The following is a description of a gene set: species: Homo sapiens Abnormal systemic blood pressure A chronic deviation from normal pressure in the systemic arterial system. Human Gene Set: HP_ABNORMAL_SYSTEMIC_BLOOD_PRESSURE, and this is the list of marker genes: CEP19, LRRK2, NF1, RYR1, IFT140, MTFMT, TREX1, FKBP6, CLCNKA, CEP290, XPNPEP3, ACP5, HLA-DRB1, IDUA, NFKB2, KCNJ1, STN1, SMAD6, ARVCF, BBS5, SERPINA6, PLAAT3, ELP1, TRPC6, TGFBR2, STAT4, VAC14, TNFSF4, LIPE, MMP14, CCND1, STAR, UBE2L3, HELLPAR, WDPCP, ENG, GIGYF2, FLT1 (fms related receptor tyrosine kinase 1), PAM16, MT-ND1, CYP17A1, IFIH1, MLXIPL (MLX interacting protein like), VPS35, MUC1 (mucin 1, cell surface associated), MYCN, CCN2, ACTG2, WDR19, AGT, EXT2, P2RY11, CDKN2A, CASR, DLL4, IL12B, NTRK1, HEY2, IFT27, SLC25A20, PRKAG2, FBN1, CIDEC, NEUROG3 (NCBI Gene Id 50674), ALX4, TNFRSF11A, LMNB1, METTL27, TXNRD2, GMPPA, RUNX1, ACTA2, ERCC6, MYMK, GNAS, COL3A1, STAT2, SMAD2, SLC12A3 (solute carrier family 12 member 3), NOTCH1, SLC7A7, MKKS, BRCA2, ACVRL1 (NCBI Gene Id 94), BANK1, OFD1, ALG9, SIM1, NOS3, CFB, PRKG1, SMAD3, HIRA, NEK8, COQ7, FIG4, KIF12, GNB3, BBS10, HGD, SFTPC, THSD1, CHRNA3, CELA2A, ALG5, CLDN1, RFC2, ZFX, SCARB2, ALK, DEF6, MT-TQ, SDHC, DNAJC13, MT-TF, PSMB9, F5, NCF1 (neutrophil cytosolic factor 1), GP1BB, PROP1, NSMCE2, MT-TK, IRF4, JAK2, ITGAM, HMOX1, BICC1, ASXL1, LYZ, HACE1, GTF2IRD1, BMPR2, MT-TW, BBS2, ENPP1, HSD3B2, MDM2, FH, PDE3A, SAA1, ADRA2A, TMEM270, ZNRF3, TMEM70, POU3F4, C4A, COL4A3, SLC30A9, TMEM127, HPSE2, BBIP1, HLA-B, MAX, TBX19, CYP11B1, HMGCL, FGFR2, SNCA, SCLT1, CD2AP, USP48, DLST, SLC35A2, IGHG1, INVS, BLK, CEP164, SPRY2, ATRX, AAAS, NKX2-5, TSC2, IFNG (interferon gamma), FN1, ABCC6, PTPN22, DDC (dopa decarboxylase), IQCB1, LIN28B, HEXB, EDA2R, TP53, DNMT3A, LZTFL1 (NCBI Gene Id 54585), ALMS1, BBS9, H4C3, TGFB3, VANGL1, TCF4, RPGRIP1L, ITGA8, ARL6, RREB1, GPR35, SCAPER, B2M, TBL2, BSND, SDHD, LOX, FOXA2, IDS, TNFAIP3, ELN, TRAPPC11, EGFR, SMARCAL1, LHX4, GUCY1A1, ABCG5, STX1A, EXOSC2, DCTN1, MC4R, FCGR2B, UBR1, PLIN1, DHCR7, POU2AF1, SLC12A1, SLC25A11, CLCNKB, NOTCH2, LMNA, EOGT, MOG, GSN, KIAA0319L, ZMPSTE24, NR4A2, EIF4H, SDHAF2, ACBD6, LDLR (NCBI Gene Id 3949), CYP11A1, COL4A4, POT1, AVPR2, CPOX, COL5A2, ETS1, THBD, NPHP3, APOA1, WNK1, CFHR1, BMP6, COQ2 (NCBI Gene Id 27235), ZFYVE19, HMBS, SCN2B, TRAF3IP1, DZIP1L, MYLK (NCBI Gene Id 50483), FGA, PIGM, PDCD1, RNU4ATAC, GEMIN4, TLR7, ALB, CTSH, PDE4D, CYP11B2, SDHA (succinate dehydrogenase complex flavoprotein subunit A), COMT, LMO1, TRIM28, GCH1, IFT74, HBB, ERCC8, MT-CO1, MT-ND5, PRKACA, IFT172, ADD1 (adducin 1), DEPDC5, FOXE3, CFHR3, KLHL3 (kelch like family member 3), DCDC2, REN, ARMC5, C3, FMR1, TNPO3, BBS4, MT-TC, KRT18, SCNN1A, APOB, GTF2I, ZNF365, ACTN4, THSD4, MYMX, SMAD4, WRN, PHF21A, MT-CYB, CTLA4, LIPA, ARSA, PBX1, ABCA3 (NCBI Gene Id 21), DOCK6, MEF2A, ANGPTL6, HLA-DQB1, TNFSF15, GTF2IRD2, FMO3, GLI2 (NCBI Gene Id 50806), SLC37A4, SDHB, MRAP, MMEL1, OSGEP, ACE, CFI, IFT56, BANF1, POU1F1, IL12RB1, EPOR, MAFB, NFIX, CTNNB1, ABCG8, SERPING1, TERT, XYLT1, SPG11, PDE11A, MEN1, SP110, BRCC3, COL5A1, ABCB6, MYH11, ITCH, LRP6, MT-ND6, IL10, VHL, CUL3, KCTD1, MPI, GATA5, JMJD1C, JAZF1, INF2, NOTCH3, SDCCAG8, C4B, CCR6, PKD2, PKD1, DNASE1, CLIP2, CALR, KCNJ5, EDA, CLCN2, ABCB4, SOX10, CACNA1H, CYP3A5, CDKN2B, MC2R, CYP21A2, HLA-DPB1, PHOX2B, SLC30A10, CORIN, IMPDH2, ERCC4, BNC2, DNAJC30, CEP83, SCNN1G, CD46, CACNA1D, PTGIS (prostaglandin I2 synthase), ARHGAP31 (NCBI Gene Id 57514), SHPK, TBX1, TSC1, SCNN1B, DYRK1B, TULP3, TGFBR3, ADAMTSL4, H19, DIS3L2, SPIB, PAX2, TGFB2, GPR101, VPS37D, MMP2, SLC2A10, MT-TS2, ASL, HESX1, SRSF2, CDKN1A, PXK, NR3C2, TNFRSF11B, PIGA, LRIG2, COL1A1, CBL, WT1, NNT, GPC3, MGP, HCRT, KDM1A, FARSB (phenylalanyl-tRNA synthetase subunit beta), TTC8, BBS1, STOX1, USP8, SUGCT, TRIP13, MT-TV, XYLT2, TGFBR1, REST, IRF5, UFD1, MLX, SOX3, CDH23, HNRNPK, LIMK1, TNNT2, SEC61A1, GLA, NPHP4 (NCBI Gene Id 261734), CFAP418, TNIP1, GIMAP5 (GTPase, IMAP family member 5), IRAK1, PSAP, GNB2, LDLRAP1, PPOX, DBH (dopamine beta-hydroxylase), MECP2, LEMD3, MBTPS2, MT-CO2, POU6F2, CHCHD2, TET2, PKHD1, AIP, NAF1, GNA11 (G protein subunit alpha 11), MST1, MED12, POR, AGTR1, LMX1B, PRTN3, EPAS1, LBX1 (ladybird homeobox 1), ECE1, CFH, GLIS3, BUD23, ATP1B1, SEC24C, CDKN2C, DNAJB11, MMACHC, MTRR, HFE, TJP2, TMEM237, EIF4G1, INPP5E, DST, FUZ, RGS5, G6PC1, HR, CLDN16, RET, MT-CO3, CDKN1B, HSD11B2, KIT, NDUFAF6, KYNU, HLA-DPA1, MFAP5, GANAB, BTNL2, MKS1, MDH2, LEP, TMEM67, BAZ1B, ABCD3, SFTPB, PRKAR1A, LARS2, CC2D2A (coiled-coil and C2 domain containing 2A), ADA2, MPL, KIF1B, CCDC28B (coiled-coil domain containing 28B), UMOD, HADHB, PRIM1, SH2B3, IL12A, MT-TL1, HTRA1, MAT2A, BBS12, GBE1, SEMA4D, APRT, BRAF, OTX2, ATP7A, WDR35, CBS, LRPPRC, CR2, CYB561, FCGR3B, LAMB2, BBS7, TRIM32, LEPR, WNK4, PCSK9, GBA1, YY1AP1, PRNP, CAV1, BSCL2, NR3C1, ACAT1, PPARG, DGUOK, COL4A5, STAT1, PRDX1, SPP1, RNU7-1, GDF2, KCNJ10, RBPJ, TTR, NOD2, NPHP1